The following is a description of a gene set: from publication Joseph J, Mudduluru G, Antony S, Vashistha S, Ajitkumar P, Somasundaram K (PMID 15318170) Genes down-regulated in H460 cells (non-small cell lung carcinoma, NSCLC) after treatment with sodium butyrate. Human Gene Set: JOSEPH_RESPONSE_TO_SODIUM_BUTYRATE_DN studied in species Homo sapiens Histone deacetylase (HDAC) inhibitors induce growth arrest and apoptosis in a variety of human cancer cells. Sodium butyrate (NaB), a short chain fatty acid, is a HDAC inhibitor and is produced in the colonic lumen as a consequence of microbial degradation of dietary fibers. In order to dissect out the mechanism of NaB-induced growth inhibition of cancer cells, we carried out expression profiling of a human lung carcinoma cell line (H460) treated with NaB using a cDNA microarray. Of the total genes analysed, there were genes with a mean expression value of 2.0-fold and higher and genes with a mean expression value 3.0-fold and lower in NaB-treated cells. For a few selected genes, we demonstrate that their expression pattern by semiquantitative reverse transcription-polymerase chain reaction (RT-PCR) analysis is matching with the results obtained by microarray analysis. Closer view at the expression profile of NaB-treated cells revealed the downregulation of a total of genes associated with cytokine signaling, in particular, interferon gamma (IFNgamma) pathway. In good correlation, NaB-pretreated cells failed to induce interferon regulatory factor 1, an INFgamma target gene, efficiently upon IFNgamma addition. These results suggest that NaB inhibits proinflammatory cytokine signaling pathway, thus providing proof of mechanism for its anti-inflammatory activity. We also found that NaB induced three genes, which are known metastatic suppressors, and downregulated genes, which have been shown to promote metastasis. Upregulation of metastatic suppressor Kangai 1 (KAI1) by NaB in a time-dependent manner was confirmed by RT-PCR analysis. The differential regulation of metastasis-associated genes by NaB provides explanation for the anti-invasive properties of NaB. Therefore, our study presents new evidence for pathways regulated by NaB, thus providing evidence for the mechanism behind anti-inflammatory and antimetastatic activities of NaB., and this is the list of marker genes: FES (FES proto-oncogene, tyrosine kinase), CKS1B, ALDH1A1, ATP7B, PYGL, GMPS, FSTL1 (follistatin like 1), THBS4, PFKL, STAT6, RNF141, IRF2, G6PC1, IL6, ALAD, NF2, EMP3, ERCC2, ALPK2, CAPN7, EIF4G2, ELK3, GRM3, F10, GAA, ELANE, THRA, CLCN3, C7, TUBA4A, NUCB1, CYP4A11 (NCBI Gene Id 1579), HSPG2, USP7, HMGB1, CDK4, CUL1, ACP2, AQP1, ZNF137P, DPP6, PRKAR2A, ABCC2 (NCBI Gene Id 1244), IL11, CDH11, CD300C, CSF1, TIMP3, SULT1E1, TXK, MPP3, NAMPT, COL6A3, A2M, NCL, ADH6, MYL4, VEGFB, THSD7A, AFF1